Given this list of marker genes TSEN54, CLDN17, GALR1, UNC80, CYSTM1, SEL1L3 (NCBI Gene Id 23231), EPN2, PKN1, MCM7, KIF13A, RARB, BCL11A, ZHX2, GRAMD2B, RAPGEF6, USP30, NPAS4, UCHL1, SESTD1, DST, CMBL, LRRC8C, LAMA4, PHLDB3, SLC7A3, FOXO3, MKNK2, MYCLP1, CKMT1B, RASGEF1B, BPTF, FOXB1, TSPAN14, MACROH2A1, JPH3, KCNQ3, GPR85, KCNV1, C6orf15, NEURL1, LRRC1, NR3C1, FAF1, PICALM, NR3C2, NSUN5P1, CLIP1 (CAP-Gly domain containing linker protein 1), PHF2, NSUN5P2 (NCBI Gene Id 260294), MPC2, JUP (junction plakoglobin), WDPCP, NPAS2, ZFHX3, SHOX2, CADM1, BRME1, EYA4, ATXN1, ZC3H18, ERF, COL25A1, OCRL, CHST11, HRH3, SHF, GABRE, ELOVL5, FAM117A, MAN1A1, NUDT11, WDR1, EHD4, BCL9, ILDR1, CSNK1A1, YPEL1, UBE2E1, SEC24D, NR4A2, RAB5C, MACO1, DGCR8, TBC1D10A, CHRNB1, HERC4, DDAH2, NKX2-8, CCDC112, SAMD11, CHCHD3, PRRX1, RYR1, RASL10B, DOC2A, PIP5K1B, MRC2, PGM3, ABR, NRF1, SNCA, SOX10, SUMO2, INHBA, NONO, SMIM10L2A, CASKIN2 (NCBI Gene Id 57513), ANXA9, NUDT10, CBLN4, LRRN3, SCN5A, SORCS3, TMEM263, HELZ2, MUSK, OSBPL11, PHYHIP, TJP1, PCBP4, RWDD2A, RIMS4, COL18A1, HUNK, SYT17, KCND2, NANOS1, ARL4A, GABARAPL2, ZER1, KCNK13, RIMS1, COX6A2, AHI1, FGF17, GAP43 (NCBI Gene Id 2596), SOX21, ATP6V1C2, ECEL1, MTUS1, TSC22D1, CACNB3, AP4M1, PGAP2, RNF43, MSI2, RERG, HCRTR1, GGN, ZIC4 (Zic family member 4), TBC1D20, HAP1, GALNT15, PNMA5, MMP16, HNRNPUL1, NOTCH1, EML4, KPNA6, YARS1, here is a description of the gene set: Comprehensive identification of all functional elements encoded in the human genome is a fundamental need in biomedical research. Here, we present a comparative analysis of the human, mouse, rat and dog genomes to create a systematic catalogue of common regulatory motifs in promoters and 3' untranslated regions (3' UTRs). The promoter analysis yields 174 candidate motifs, including most previously known transcription-factor binding sites and 105 new motifs. The 3'-UTR analysis yields 106 motifs likely to be involved in post-transcriptional regulation. Nearly one-half are associated with microRNAs (miRNAs), leading to the discovery of many new miRNA genes and their likely target genes. Our results suggest that previous estimates of the number of human miRNA genes were low, and that miRNAs regulate at least 20% of human genes. The overall results provide a systematic view of gene regulation in the human, which will be refined as additional mammalian genomes become available. species: Homo sapiens from publication Xie X, Lu J, Kulbokas EJ, Golub TR, Mootha V, Lindblad-Toh K, Lander ES, Kellis M (PMID 15735639) Human Gene Set: ACCTGTTG_UNKNOWN Genes having at least one occurrence of the highly conserved motif M57 ACCTGTTG in the regions spanning 4 kb centered on their transcription starting sites. The motif does not match any known transcription factor binding site.